The following is a description of a gene set: from publication Yevshin I, Sharipov R, Kolmykov S, Kondrakhin Y, Kolpakov F (PMID 30445619) Human Gene Set: ZNF507_TARGET_GENES studied in species Homo sapiens Genes containing one or more binding sites for (ZNF507) in their promoter regions (TSS -1000,+100 bp) as identified by GTRD version 20.06 ChIP-seq harmonization., and this is the list of marker genes: TDG (NCBI Gene Id 93091, thymine DNA glycosylase), GALC, GUSB, TPP1, NEU1, PWWP2A, PBXIP1, LRRC37A3, LINC02231, FADS2, USP31, OSBPL2, ATXN1L, MAF, AHCYL2, PDCD6IP, GPNMB, VPS26A, VPS35L, RPS29P16, STX4, ZRANB2-AS1, HNRNPD, NTMT1, DDX19B, SOCS5, SETP9, HPS3, SPOCD1, HOXC13, C1orf43, SNORD49B, C4orf3, ATP6V0B, SREK1, SDHC, KDM3A, HPS5, RBM28, MIR4661, SLC35A5, NEURL2, TBCEL, ATP6V1C1, AFF4-DT, ANKRD13A, ZNF778, C6orf52, EFTUD2, TAMM41, GTF2A1, KLHL12, CREBRF, TSC2, CLCN6, LEMD3, UQCC6, TRMT10B (NCBI Gene Id 158234), SEMA4C, OR10H4, VAV3, DYM, UBAP2L, RNFT2, DTNA, CRB3, TMEM131, C1QTNF6, CCDC115, WBP2, WASHC2C, PPM1H, CUTA, MIR550B1, CHMP4A, GET3, GATB, LAMP1, RAET1K, SH3BP2, MFF, STK25, ATP6V1H, CNPPD1, GALNS, TCN1, RAMACL (NCBI Gene Id 353267), TSC1, RCAN1, ARHGAP12, PLCG1-AS1, HSD11B1L, MIR550A1, ITGA7, RETREG2, TMEM232, MTHFR, NPTN, FEN1, MCOLN1, HEXA, AKT2, MVP-DT, HMGCS2, BLOC1S3, MRPL30, WDR81, OTUD3, HNRNPD-DT, OPLAH, FOXM1, MIR8059, UGGT1, TMEM126B, VPS8, TMEM116, PEPD, UBE2Q1, MIR3928, FAM13A, LIMA1, RAD50, LACTB2, FAM118B, FAM21EP, DPH6, SLC3A2, COMMD4, RIT1, TNFAIP3, IST1, POLDIP2, STEEP1, SUPV3L1, SNRPA, BCL2L13, ALDH6A1, FBXO38, DEPDC1, GLMP, UBAP2, PFKFB2, STX6, ACIN1, VEPH1, RELB, UTP20, IGF2R, MFF-DT, PIP4P1 (phosphatidylinositol-4,5-bisphosphate 4-phosphatase 1), DHX35, AKAP11, MRPL41, COMMD8, ZNF292, SUB1, AGTRAP, METAP1D, GLA, VPS11-DT (NCBI Gene Id 124902769), WWP2, UBE2B, RPUSD4, GPATCH3, THRAP3, ZFP62, UBXN1, MAP2K4P1, MIR550A2, MRPL27, USP44, EFHB, EIF4B, MTRF1LP1, SKIC3, LGALS8, ERP29, CTSA, TNPO2, FAM117A, CLCN5 (chloride voltage-gated channel 5), DDX3X, DVL2, PIP4K2C, PAGE5, LINC00652, ADAR, GIGYF2, MAX, PKD1L2, CTNS, MRPS18C, TSR3, NDUFAF5, CDK4, PTEN, SRSF2, NAA50, ABCB6, TMEM258, MAP3K12 (NCBI Gene Id 7786), NOS3, LCDR, RPP30, CHCT1, PES1, UBE4B, DUSP7, ATP6V0D1, GTF2H1, TMEM185B, GFI1B, CCDC103, PICALM, FAM210A, PET117, GTF2A1-AS1, MARF1, RAB21, BROX, THAP8, UQCRC2, ARSK, TMEM126A, HDAC4-AS1, ANKRD12, ICA1L, GNS (glucosamine (N-acetyl)-6-sulfatase), CAMK2D, MIR6879, LINC01278, SNIP1, LINC01285, RAB5A, IKBKG, ENSG00000258623, ASXL2, FERRY3, MCMBP, C12orf43, KLHL24, MAP1LC3B, DENND6A-DT, SLC25A26 (NCBI Gene Id 115286), HEG1, MCPH1-AS1, DHX35-DT, XKR3, ILVBL, PDGFB, MIR181A1HG, KAT14, LGALS8-AS1, LMTK2 (lemur tyrosine kinase 2), HEXA-AS1, SRPK2, PDE12, EFCAB13, CASP9, CLCN7, CALR, SLC25A38, ENSG00000282904 (novel transcript), RPL36, KAT7, ADNP2, IFI30, PABPN1, LINC01480, PALB2, PLA2G4C, CLN3, LINC02851, NAGPA, PLD3, TADA1, CD70, HAGH, SYT12, SGO1, VPS35, ORC6, SEC23IP, WDR6, ADCK1, EPC1-AS2, TAF6L, HELQ, ATP7A, ENSG00000260830, ISLR2, TBC1D17, UROD, USPL1 (ubiquitin specific peptidase like 1), CHIC1, DIAPH1, LAPTM4A-DT, HPS1, HSPBAP1, CDKL3, STT3A, AIDA, SBNO2, SEL1L3, HAPSTR1, ADNP, XKR9, RNMT, TOM1L2, NRBF2, TOM1, SASH1, EEF2, ZFYVE26, TOGARAM1, TRMT1, LRPPRC, HMGCL, ANKRD10, GUF1, NPY1R, WDR19 (NCBI Gene Id 80203), FTH1P5, CDK16 (NCBI Gene Id 5127), MIGA2, CDK7, EME1, CDK20, EIF2S1, ATG3, ZNF322, PHTF2, PARL, LATS2, SOCS2, MBD6, PPP1R26, LAMTOR1, USP28, PCM1, GEM, ACOX1, KIF16B, RAB3GAP2, HMOX1, CD164, TCEAL4, RAD51AP1, VPS18, VPS33A, CAPZA2, ILF3, SLC25A36, PPIL4, ADI1P3, IGHD3-3, USP32, RNF220, HERPUD1, ALG1, ZNF507, GRN, TRAPPC8, GET4, DUS3L, ARL2, ZZZ3, TPRA1, SIRT6, NOL8, CRACDL, DLG2, MITD1, PIK3C2A, YOD1, WASHC5, RIOK3, POLD1, S100PBP, RIMOC1, BHLHE40, MRPS2, SYNE1, ALDH1A2, COMMD3-BMI1, HCFC1R1, MELTF-AS1, HDAC4 (NCBI Gene Id 9759), EIF4A3, RPL22P17, FAM187A, AKT1S1, BCL6, ATP6V1A, IL5 (interleukin 5), BAX, HECTD3, IGLV1-47, FAM9CP1, CHCHD2P6, LINC02863, ATP6V1D, GBA1, MED28, ZFYVE1, COL9A2, SKAP2, ENSG00000260288, NAPSB, RRAGC-DT, RNF181, MFSD1, TOP3A, DOLK, SRSF3, MILIP, NR6A1, COX7A2L, CCDC167, RHCG, RNU6-829P, MPV17, PTBP1, SCAMP3, EFCAB10, SLMAP, RBM19, INTU, RNF185, TSR2, TULP3, ISG20, RNU7-27P, SLC38A2 (NCBI Gene Id 95454), SLC33A1, MVP, RAD9A, SIRT5, MIR3910-2, GIT2, CCNT1 (NCBI Gene Id 904), AVL9, FNIP2, KAT5, HOXB7, XIST, C19orf47, UBALD2, DCTN4, ACTMAP, AMDHD2, RNF43, SPPL3, LINC01881, SMNDC1, USF1P1, GABARAP, PNPLA7, COA7, LSM5, RCBTB1, DOHH, SPNS1, SCLY, RNASEK-C17orf49, RHNO1, DTX3, MIR550B2, MOV10, CENPP, VPS11, SAE1 (NCBI Gene Id 51502), NFATC3, NUDC, ATP6V0D1-DT, SLC25A32, HNRNPH2, SLC36A1, GDF15, RUFY1, VAC14, TMEM199, SCAMP4, PIERCE1, GNPTG, NUP188, ZDHHC1, DHDDS, FNIP1, PPP4R1, IMP4, SLC25A12, DYRK1A, MIR548AW, LAMTOR3, ATG14, DENND6A, MED28-DT (NCBI Gene Id 121232375), MARCHF8, SMIM27, MFSD13A, PLA2G6, PENK-AS1, ATP6AP1-DT, MORC2, IQSEC1, QTRT1, ANKRD40CL, CUL5, AP5Z1, CHM, BPTF, RBM15, ZNF780A, IFRD1, MFSD11, GBA1LP, RAB7A, VPS41, APEX1, NAA40, NSMCE2, EMC2, UVRAG, RNASEK, LINC01164, SLC35B2, ATXN7L1, FNDC3A, WASHC2A, GNPDA1, CCNG2, HIF1A, OR10H3, G3BP1P1, NUDCD3, SPG21, SERF2, ENSG00000266313 (novel transcript), MCM2, C4orf46P2, SLC49A4, SUMF1, NAPA, PRDX6, SIRT1, C7orf25, LAPTM4A, RBM15-AS1 (NCBI Gene Id 440600), ZBTB8OS, MFSD5, MAFG, LDHBP1, SBNO1, COMMD3, ARFGEF2, WDR62, DRC3, RBBP4, OSGEP, LINC00649, SQSTM1, TRAPPC2L, SHPK, KIDINS220, FUCA2, FLCN, DDB2, MTHFD2P2, TCN2, MICOS13, DCAF13, DUSP3, ATP6V1G1, FAM21FP, AFF4, VPS50, HOXC5, LIN52, COX5A, ANAPC5, BCL7C, TNRC6B, FDX2, RRAGB, ESF1, RNVU1-2A, AARS1, CEP162, ZNF815P, DNAJC8, CDIPT, PAK1IP1, PRRC2C, ADAT3, CTSD, CCAR1, PMEL, TRAPPC6A, DNAJC16, SGO1-AS1, EPC1-AS1, RAB5B, BLOC1S1, RNU4-42P, SLC38A2-AS1, RC3H2, SLC38A7, FBXO31, FBXO38-DT (NCBI Gene Id 124901185), RN7SKP114, ATP6AP1, RBM48P1, SSR3, SYNE2, KCNG3, SMCR8, GNB2, ATP6V1E1, ENSG00000272008, EFCAB13-DT, DNAJC13, ASPSCR1, ILF3-DT, NTHL1, MAPK3, LNPK, RRAGC, VAPB, PPT1, SUPT16H, RMND1, SPRING1, BPHL (biphenyl hydrolase like), LINC-PINT, SLC25A46, EPG5, EIF4A1 (NCBI Gene Id 1973), CDIPTOSP, SEPHS2, DIP2B, ALG10B, SNHG29, STK3, HBP1, ATP6V0C, TEX10, KDM4C, COMMD9, COQ4 (NCBI Gene Id 51117), UBXN6, GUSBP11, DCTN5, FAHD1, NDUFV2-AS1 (NCBI Gene Id 101927275), ARRDC1, ACAD9, AP1AR-DT, DUSP1, ARL8B, GPRASP3, KLHL28, ARMT1